The following is a description of a gene set: Human Gene Set: MIR6775_3P Genes predicted to be targets of miRBase v22 microRNA hsa-miR-6775-3p in miRDB v6.0 with MirTarget v4 prediction scores > 80 (high confidence targets). from publication Chen Y, Wang X (PMID 31504780) species: Homo sapiens, and this is the list of marker genes: TGM4, PGM5, MYORG, TIMM22, MAGEA11, LMOD1, KIAA1549, ZHX1-C8orf76, IQSEC2, TAB1, PGAP3, GPM6A, USP37, FHIP1B, USP45, FBXO10 (NCBI Gene Id 26267), MBNL3, CES3, ARL4C, CDC42EP1, FOXP4, NF2, MAN1C1, KCNQ5, UNC13B, RGS9BP, ESYT1 (extended synaptotagmin 1), VASH1, IQCE, ST6GALNAC6, TIAM1, CUX1, MFSD14B, REEP2, XKR7, EDC3, IL1B (interleukin 1 beta), ELOVL5, VSIG4, NPTXR, MECP2, CABP7, CYP2C18, CEMIP2, ACAP3, PTPRU, ODF2, PAK2, VWA5A, ENTREP2, GLYCTK, SNRPB, DYNC1I1, SLC6A3, PLA2G4C, ETV6, MUC22, FAM153A, IMPA2 (NCBI Gene Id 3613), CD79A, CCDC97, WNT11, ERMP1, IQSEC3, FBXO41, CYB561A3, PTPA, H2AX, ARID3B, KIAA0319L, RASSF1, RALGDS, SH3PXD2A, RASAL2, RBFOX1, KLHDC10, DNAJB5, FAAP100, SHKBP1, NRIP1, OAZ2, ZMIZ1